The following is a description of a gene set: species: Mus musculus Mouse Gene Set: GOBP_ESTABLISHMENT_OR_MAINTENANCE_OF_CELL_POLARITY_REGULATING_CELL_SHAPE Any cellular process that results in the specification, formation or maintenance of a polarized intracellular organization or cell growth patterns that regulate the shape of a cell., and this is the list of marker genes: Cfl1, Parvg, Kif3a (kinesin family member 3A), Mark2, Parva, Parvb